The following is a description of a gene set: The reproductive process in which the parent is separated from its offspring either by giving birth to live young or by laying eggs. studied in species Homo sapiens Human Gene Set: GOBP_PARTURITION, and this is the list of marker genes: PLA2G4C, RXFP1, NODAL, CYP1A1, HPGD, PLA2G4B, LDOC1, PTGFR, MMP2, CRH, CRHR1, EDN1, MAFF, OXTR